The following is a description of a gene set: species: Mus musculus Any process that stops, prevents, or reduces the frequency, rate or extent of the migration of the endothelial cells of blood vessels. Mouse Gene Set: GOBP_NEGATIVE_REGULATION_OF_BLOOD_VESSEL_ENDOTHELIAL_CELL_MIGRATION, and this is the list of marker genes: Klf4, Hrg, Meox2, Tnf, Prl7d1 (NCBI Gene Id 18814), Rgcc, Stard13, Robo4, Map2k5, Mef2c, Hmgb1, Thbs1, Angpt4, Tgfb1, Card10, Mmrn2, Tbxa2r, Acvrl1, Rhoa, Spred1 (sprouty protein with EVH-1 domain 1, related sequence), Apoe, Gadd45a, Pik3r2, Pdcd10, Mmrn1, Jup, Pparg, Itgb1bp1, Notch1, Csnk2b, Angpt2, Hdac5, Vash1, Fgf2, Mecp2, Dll4, Atp2b4 (ATPase, Ca++ transporting, plasma membrane 4)